The following is a description of a gene set: Mouse Gene Set: GOBP_RESPONSE_TO_FLAVONOID studied in species Mus musculus Any process that results in a change in state or activity of a cell or an organism (in terms of movement, secretion, enzyme production, gene expression, etc.) as a result of a flavonoid stimulus., and this is the list of marker genes: Dnm1l, Abcb1a, Nqo1, Ip6k2, Higd2a